The following is a description of a gene set: Any process that stops, prevents, or reduces the frequency, rate or extent of microtubule polymerization. Human Gene Set: GOBP_NEGATIVE_REGULATION_OF_MICROTUBULE_POLYMERIZATION species: Homo sapiens, and this is the list of marker genes: STMN1, STMN2, TBCD, CLIP3, EML2, TUBB4A, MAPRE1, INPP5J, MAP2, CDH5, DYRK1A, SNCA, FKBP4, ARHGEF7